Given this list of marker genes SLC25A5 (NCBI Gene Id 292), GCLC, IER3, ACAA2, SLC25A4, HSPA1A, BCL2L1, SLC25A31 (NCBI Gene Id 83447), BOK, FZD9, SLC25A6, MPV17L, SLC35F6, BAK1, TMEM14A, here is a description of the gene set: species: Homo sapiens Human Gene Set: GOBP_NEGATIVE_REGULATION_OF_MITOCHONDRIAL_OUTER_MEMBRANE_PERMEABILIZATION_INVOLVED_IN_APOPTOTIC_SIGNALING_PATHWAY Any process that stops, prevents or reduces the frequency, rate or extent of mitochondrial outer membrane permeabilization involved in apoptotic signaling pathway.